The following is a description of a gene set: In glioblastoma, the most prevalent EGFR mutation, present in ~25% of tumors, is the deletion of the ligand binding domain of EGFR, accompanied with amplification of the mutated allele, which results in over-expression of the mutant protein known as EGFRvIII. EGFRvIII mutant is not able to bind a ligand, but dimerizes and autophosphorylates spontaneously and is therefore constitutively active. Point mutations in the extracellular domain of EGFR are also frequently found in glioblastoma, but ligand binding ability and responsiveness are preserved. <br>Similar to EGFR kinase domain mutants, EGFRvIII mutant needs to maintain association with the chaperone heat shock protein 90 (HSP90) for proper functioning. CDC37 is a co-chaperone of HSP90 that acts as a scaffold and regulator of interaction between HSP90 and its protein kinase clients. CDC37 is frequently over-expressed in cancers involving mutant kinases and acts as an oncogene. <br>Expression of EGFRvIII mutant results in aberrant activation of downstream signaling cascades, namely RAS/RAF/MAP kinase signaling and PI3K/AKT signaling, and possibly signaling by PLCG1, which leads to increased cell proliferation and survival, providing selective advantage to cancer cells that harbor EGFRvIII. <br> EGFRvIII mutant does not autophosorylate on the tyrosine residue Y1069 (i.e. Y1045 in the mature protein), a docking site for CBL, and is therefore unable to recruit CBL ubiquitin ligase, which enables it to escape degradation part of: Signaling by EGFRvIII in Cancer studied in species Homo sapiens Reactome Pathway: Constitutive Signaling by EGFRvIII, and this is the list of marker genes: GAB1, NRAS, PLCG1, EGFR, PIK3R1, PIK3CA, SOS1, CBL, HSP90AA1, GRB2, CDC37, HRAS, KRAS (KRAS proto-oncogene, GTPase), SHC1, EGF